The following is a description of a gene set: Any process that modulates the frequency, rate or extent of postsynaptic specialization assembly, the aggregation, arrangement and bonding together of a set of components to form a postsynaptic specialization. Human Gene Set: GOBP_REGULATION_OF_POSTSYNAPTIC_SPECIALIZATION_ASSEMBLY studied in species Homo sapiens, and this is the list of marker genes: LRRTM2 (leucine rich repeat transmembrane neuronal 2), PTPRS, LATS1, SPTBN2, LRFN1, PTK2B, PRICKLE1, PTPRD, CBLN1, CASKIN1, FGFR1, ABL1, ABI3, IL1RAP (NCBI Gene Id 3556), GRID2, GAP43, LRFN4, LRRC4B, ARHGEF9, CRIPT